The following is a description of a gene set: Human Gene Set: GOBP_ESTABLISHMENT_OF_PROTEIN_LOCALIZATION_TO_PEROXISOME The directed movement of a protein to a specific location in a peroxisome. studied in species Homo sapiens, and this is the list of marker genes: PEX7, PEX5, PEX16, PEX6, TRIM37, USP9X, RAB8B, PEX5L, PEX2, ZFAND6, PEX1, PEX19, PEX10, PEX13, LONP2, PEX3, PEX12, PEX26, PEX14, HACL1